The following is a description of a gene set: species: Homo sapiens from publication Chen Y, Wang X (PMID 31504780) Genes predicted to be targets of miRBase v22 microRNA hsa-miR-6741-5p in miRDB v6.0 with MirTarget v4 prediction scores > 80 (high confidence targets). Human Gene Set: MIR6741_5P, and this is the list of marker genes: STMN3, CMTR1, TAF5, MXD1, SPN, ARL4C, TMEM40, INO80D, PCTP, HNRNPA1L2, PAPPA, MAP3K6, DNALI1, SCG3, ARV1, CHRNG, ATP2B4, TRIM10, FBXW11, ADGRL1, FLVCR1, SAMD4A